The following is a description of a gene set: Impairment in the physical production of speech sounds. Human Gene Set: HP_SPEECH_ARTICULATION_DIFFICULTIES studied in species Homo sapiens Speech articulation difficulties, and this is the list of marker genes: CDH1, NDN, GRIN2A, IRF6, DLG1, HTT, COBLL1 (cordon-bleu WH2 repeat protein like 1), MAGEL2, MSX1, NECTIN1, SNRPN, STAG2, GABRG2, GRHL3, OCA2, SMAD4, DLX4, SLC2A3, ARHGAP29, UBB, SH2B1, GNAI3, MAPT, TP63, GALT, FOXP1, RIC1, NF1, BMP4, SRPX2, PDGFRA, PLCB4, FRRS1L, ALDH4A1, ARHGEF38